The following is a description of a gene set: eNOS activation studied in species Homo sapiens Human Gene Set: REACTOME_ENOS_ACTIVATION, and this is the list of marker genes: DDAH1, NOS3, CYGB, ZDHHC21, AKT1, NMT2, CAV1, NMT1, SPR, CALM1 (NCBI Gene Id 801), HSP90AA1, CYB5B, LYPLA1